The following is a description of a gene set: studied in species Homo sapiens Recurrent sinopulmonary infections An increased susceptibility to infections involving both the paranasal sinuses and the lungs, as manifested by a history of recurrent sinopulmonary infections. Human Gene Set: HP_RECURRENT_SINOPULMONARY_INFECTIONS, and this is the list of marker genes: STAT3, ODAD1, DNAAF6, ODAD3, DNAAF3, TFRC, PLCG2, NBN, DNAAF5, CFAP298, CFAP221, NME8, CTNNBL1, DNAH9, GFI1, DNAL1, DNAI1, DNAH11, DNAAF11, DRC1, DNAI2, CCNO, RSPH9, TNFRSF13B, SPAG1, RSPH1, SPEF2, ODAD4, TTC12, RPGR (NCBI Gene Id 6110), PIK3CD, GAS2L2, CASP8, SRP19, CCDC39 (coiled-coil domain 39 molecular ruler complex subunit), DNAAF1, DOCK8, NME5, LRRC56, STK36, RSPH4A, DNAH1, NEK10 (NIMA related kinase 10), CLPB, TCIRG1, ATP6V0A2, CFAP300, DNAJB13, BACH2, ZMYND10 (zinc finger MYND-type containing 10), NFKB1, OFD1, DNAH5, PIK3CG, CFTR, MCIDAS, FOXJ1, ODAD2, HYDIN, DNAAF4, DNAAF2, CCDC40, RSPH3, ELANE, CFAP74